Given this list of marker genes GTF2E2, TCP11L1, IPO7, MRM2, PAM16 (NCBI Gene Id 51025), SHMT2, ZBTB20 (NCBI Gene Id 26137), SLC25A12, ACTMAP, CXCR5, HUS1, CD164, PPP1R13L, JAM3, AGO4, CYFIP1, PHB1, OAS2, MAN2A2, HES1, ELMO1, ITM2A, PEX11A, RRAS2, FMO5, CACYBP, CENPM, DGKQ, RING1, SCAF8, CLMN, CUBN, ELP1, DAAM1, TUBGCP4, NIPSNAP3B, ID2, NFIB, RBM26 (RNA binding motif protein 26), YLPM1, DDX18, BHLHE40, MICALL1, OXR1, PNKP, BTBD7, PDZK1, NR4A2, RBM12B, DUOX1, NR3C2, FBXO28, KIAA1614, KPNA4, SLC8B1, ARHGAP19, SUV39H1, RPL28, DHX29, TRPC1, PCNT, RXRB, MTMR3, STK19 (NCBI Gene Id 8859), ZNF692, KMO, USE1, KCTD20, DIAPH2, STK10, CDADC1, MTF2, MAPK8IP1, ABCA1, SLC35A1, TBC1D1, PMS2, PHLPP1, USP9X, PANX1, NF1, PALS1, MKRN2, ANGEL2, PNN, PPP2R1B, HERC1, USP34, MCTS1, SGPP1, HGFAC, CFLAR, DGCR8, RAPGEF3, NCLN, F11, SNRK, MED31, NFATC3, SKIL, NHP2, SNED1, EVI5, MCM3AP-AS1, DMXL1, ANKMY1, VPS37B, CORO2B, DNAJC8, ANAPC1, GNA12, NECAP1 (NCBI Gene Id 25977), SC5D, TBL1XR1, SELENOW, INPP5F, BCL7B, SPON1, SEPTIN9, SOX4, NOX1, MEF2D, TAF6L, LRRC37A3, WSB1, GTF2IRD2B, BACH2, OLFML2A, SFT2D2, MYO7A, PCMT1, DCLRE1C, CAVIN1, SMPD1, PSEN1, SMAD3, WIPF2, PDAP1, WASL, CD302, ACTR1A, USP36, ZNF576, PMS2CL, RBBP9 (NCBI Gene Id 96678), CCDC25, TMOD1, SLC35F2, DCAF11, HIPK2, MRPS18C, CLN8, FGF18, SLC31A1, HOPX, TOR3A, GALNT7 (polypeptide N-acetylgalactosaminyltransferase 7), AGO1, BACE2, N4BP2L2, UTP14C, WIPI1, SPTBN1, SNX24, YIPF5, DKC1, DHX9, PFKM, ASS1, SORL1, GTF2IRD2, NOD1, APOL5, TIMM23, UBE3A, WNT16, PER2, LAMA5, ZNF264, FADS1, MAPK13, FASTKD3, TMEM222, ZNF107, KHSRP, APPBP2, AMT, USP39, CDC42EP3, FOXO3, ATN1, MIS18A, MPDU1, PARM1, FKBP4, ID2B, GNB1, COBLL1, EPS15L1, KRT3, NAA50, PAX3 (NCBI Gene Id 5077), TBPL1, DENND2D, RBM41, NDRG2, TUBGCP3, NFATC2IP, CLEC7A (NCBI Gene Id 64581), TMSB15B, RCAN1, VGLL4, SLC1A4, ETF1, NCOA2, RBPMS, ARID1A, ZNF81, SCUBE3, ANKRD11, MTSS1, PGLS, RBPJ, ACIN1, LYST, CREM, GALNT11, RNH1, CFAP298, PRUNE1, TFDP2, AGRN, IL6, TPD52, LAMC1, NPAT, NFYC, CROCCP2 (NCBI Gene Id 84809), COPS7A, RNF187, UBE2O, LSM1, NUP43, TNFRSF4, ZMAT3, SIGIRR, ING2, HR, PALB2, SDHD, EIF4G2, SLC19A2 (solute carrier family 19 member 2), DIDO1, TNS3, NEU1, PAPOLA, GPD2, AKAP13, WWP1, KLHL20, SPEN, TIMM23B, TGFB1, PPM1B, TDG, SAFB, SSBP3, DICER1, FGFR2, FEM1B, AFF3, MGMT, BTN3A1, USP10, LANCL1, RBFOX2, PSD3, OGT, UBE2H, BTN2A1, DYRK2, ARHGEF9, IFI35, ZDHHC14, ZNF35 (NCBI Gene Id 7584), SLC35E3, TTBK2, TMEM127, TRIM33, TGM4, RAB28 (NCBI Gene Id 9364), FYCO1, TLE1, LETM1, here is a description of the gene set: Here we have used a systems biology approach to study innate and adaptive responses to vaccination against influenza in humans during three consecutive influenza seasons. We studied healthy adults vaccinated with trivalent inactivated influenza vaccine (TIV) or live attenuated influenza vaccine (LAIV). TIV induced higher antibody titers and more plasmablasts than LAIV did. In subjects vaccinated with TIV, early molecular signatures correlated with and could be used to accurately predict later antibody titers in two independent trials. Notably, expression of the kinase CaMKIV at day 3 was inversely correlated with later antibody titers. Vaccination of CaMKIV-deficient mice with TIV induced enhanced antigen-specific antibody titers, which demonstrated an unappreciated role for CaMKIV in the regulation of antibody responses. Thus, systems approaches can be used to predict immunogenicity and provide new mechanistic insights about vaccines. Human Gene Set: NAKAYA_B_CELL_FLUARIX_FLUVIRIN_AGE_18_50YO_7DY_DN studied in species Homo sapiens Genes down-regulated in B cell 7d vs 0d in young adults (18-50) after exposure to Fluarix/Fluvirin, time point 7D from publication Nakaya HI, Wrammert J, Lee EK, Racioppi L, Marie-Kunze S, Haining WN, Means AR, Kasturi SP, Khan N, Li GM, McCausland M, Kanchan V, Kokko KE, Li S, Elbein R, Mehta AK, Aderem A, Subbarao K, Ahmed R, Pulendran B (PMID 21743478)